Given this list of marker genes Abcb11, Abcc1, Abcg4, Abcc3, Abcg1, Abcd1, Abcc4, here is a description of the gene set: studied in species Mus musculus Mouse Gene Set: GOMF_ATPASE_COUPLED_LIPID_TRANSMEMBRANE_TRANSPORTER_ACTIVITY Enables the transfer of a solute or solutes from one side of a membrane to the other according to the reaction: ATP + H2O + lipid(in) = ADP + phosphate + lipid(out).